The following is a description of a gene set: from publication Peart MJ, Smyth GK, van Laar RK, Bowtell DD, Richon VM, Marks PA, Holloway AJ, Johnstone RW (PMID 15738394) species: Homo sapiens Cell proliferation genes up-regulated by histone deacetylase (HDAC) inhibitors SAHA and depsipeptide. Human Gene Set: PEART_HDAC_PROLIFERATION_CLUSTER_UP Histone deacetylase inhibitors (HDACis) inhibit tumor cell growth and survival, possibly through their ability to regulate the expression of specific proliferative and/or apoptotic genes. However, the HDACi-regulated genes necessary and/or sufficient for their biological effects remain undefined. We demonstrate that the HDACis suberoylanilide hydroxamic acid (SAHA) and depsipeptide regulate a highly overlapping gene set with at least 22% of genes showing altered expression over a 16-h culture period. SAHA and depsipeptide coordinately regulated the expression of several genes within distinct apoptosis and cell cycle pathways. Multiple genes within the Myc, type beta TGF, cyclin/cyclin-dependent kinase, TNF, Bcl-2, and caspase pathways were regulated in a manner that favored induction of apoptosis and decreased cellular proliferation. APAF-1, a gene central to the intrinsic apoptotic pathway, was induced by SAHA and depsipeptide and shown to be important, but not essential, for HDACi-induced cell death. Overexpression of p16(INK4A) and arrest of cells in G(1) can suppress HDACi-mediated apoptosis. Although p16(INK4A) did not affect the genome-wide transcription changes mediated by SAHA, a small number of apoptotic genes, including BCLXL and B-MYB, were differentially regulated in a manner consistent with attenuated HDACi-mediated apoptosis in arrested cells. We demonstrate that different HDACi alter transcription of a large and common set of genes that control diverse molecular pathways important for cell survival and proliferation. The ability of HDACi to target multiple apoptotic and cell proliferation pathways may provide a competitive advantage over other chemotherapeutic agents because suppression/loss of a single pathway may not confer resistance to these agents., and this is the list of marker genes: APBB2, ORC4, CETN2, CGRRF1, MLX (NCBI Gene Id 6945), TPD52L2, NDN, RECK (reversion inducing cysteine rich protein with kazal motifs), QSOX1 (NCBI Gene Id 5768), SEPTIN8, DCTN3, MAPRE2, CDC37, CREG1, CCNF, SESN1, ID3, CDK2, FAM89B, BLM, ANLN (anillin, actin binding protein), CDKN3 (cyclin dependent kinase inhibitor 3), CKS2, HDAC3, BTG1, NEK2, TREX1, STIM1, CDC6, SLC12A6, DCTN1, PPP1CC, ID2 (NCBI Gene Id 3398), BLZF1, PRDX1, KLF10, INSIG1, RAP1A, STAMBP, ARHGAP35, TOB1, SIRT2, ING1, KPNA2 (karyopherin subunit alpha 2), CCNE1, TUSC2, CDC34, CDC25C, DUSP1, CCNG1, HDAC5, BTG2, KIF2C (kinesin family member 2C)